Given this list of marker genes Sulf1, Bmp4, Ar, Wnt5a (wingless-type MMTV integration site family, member 5A), Bmp7, Shh (NCBI Gene Id 20423), here is a description of the gene set: studied in species Mus musculus Any process that modulates the rate, frequency, or extent of prostatic bud formation, the morphogenetic process in which a region of the fetal urogenital sinus epithelium is specified to become the prostate, resulting in prostate bud outgrowth. Mouse Gene Set: GOBP_REGULATION_OF_PROSTATIC_BUD_FORMATION